The following is a description of a gene set: Mouse Gene Set: GOBP_PROGRAMMED_CELL_DEATH_IN_RESPONSE_TO_REACTIVE_OXYGEN_SPECIES Cell death resulting from activation of endogenous cellular processes and occurring as a result of a reactive oxygen species stimulus. Reactive oxygen species include singlet oxygen, superoxide, and oxygen free radicals. studied in species Mus musculus, and this is the list of marker genes: Foxp1 (NCBI Gene Id 73231), Map2k4, Ddr2, Hgf, Stk25, Pink1, Foxa1, Trap1, Hk3, Foxo3, Pjvk, Rack1, Ep300, Endog, Met, Park7, Pdcd10, Pawr